Given this list of marker genes RBCK1, BAAT, PHKG2, PALB2, NKX2-5, SLC37A4, RNASEH2B, PGM1, ANK1, PEX14, NR1H4, DUOXA2, SPTB, SLC2A1, PEX12, BRCA2, TPO, VPS50, CYP27A1, DZIP1L, TP53, FH, IL12A, TNPO3, HNF1B, CTRC, PRSS2, F5, MTR, TREX1, PEX10, RINT1, POLG, SLC5A5, VIPAS39, BCS1L, MMEL1, ABCD1, ABCB11, LRP5, SP110, CPOX, KRAS, STX11, LSM11, ASAH1, SEC63, ARL13B, SC5D, POMC, LYST, IFT56, IL2RG, AP1B1, CFTR, SLC2A2, NSD1 (nuclear receptor binding SET domain protein 1), HYOU1, PHKA2, PIGA, COG6, TRMU, GNB2, LIPA (NCBI Gene Id 3988), DEF6, GLIS3, HBG2, TCF4, TULP3, EARS2, DHFR, SMAD4, PKHD1, IRF5, FARSB, KMT2D, CPA1, IL12RB1, IYD, TNFSF15, NPHP3, PERCC1, TFAM, GALM, IFT140, ABCB4, SLC30A10, ARG1, PFKM, PEX5, PEPD, KRT18, DHCR7, TRHR, FOXE1, CEP83, PRSS1, GCLC (glutamate-cysteine ligase catalytic subunit), PCSK1, IFT172, PEX6, HMGCL, ALG6, RNU7-1, HBB, SEC23B, LHX4, KYNU, GFM1, FCGR3B, NKX2-1, STXBP2, BCAP31, PKD2, LBR, HSD17B4, SLC16A2, SLCO1B3, TRAF3IP1, MPV17 (mitochondrial inner membrane protein MPV17), SPOP, CYP7B1, LPL, SLC10A1, NPC1, NBAS, ANKS6, GNAS, PEX3, POU1F1, HK1, LYN, ETFB, SLCO1B1, JAG1, KIF23, CASR, ZFYVE19, RAB27A, ATP6AP1, ABCD3, CCDC115, MST1, RNU4ATAC, HADHB, AP1S1, IARS1, PROP1, TG, SPIB, TJP2, GYPC (glycophorin C (Gerbich blood group)), SPINK1, RFX6, SLC26A4 (solute carrier family 26 member 4), UNC13D, HTRA2, DPAGT1 (NCBI Gene Id 1799), FOCAD, ADAR, ACADVL, ATP11C, PEX11B, BRCA1 (BRCA1 DNA repair associated), SERPINA1, CLDN1, EPB41, TRPV6, SLC51B, CDIN1, CDKN2A, HADHA, SLC25A13, PRKAR1A, KMT2E, PRPS1, GALT, COX4I2, CA5A, ROS1, MMACHC, HSD3B7, MED12, EIF2AK3, RHCE, SCO2, IFIH1, ATP8B1, TBX19, STX5, KIF12, SAMHD1, PIEZO1, SLC44A1, UBR1, NEK8, FGA, PRF1, TSHR, RHD, CASK, G6PD, PEX1, SPTA1, MYO5B, GALK1, CTCF, HESX1, SAA1, IL18BP, GH1, DGUOK, SLC51A, UROS, SPTBN1, PARS2, APC2, ALDOA, VPS33B, ADAMTS13, RNASEH2C, DNASE2, EPB42, ZNF699, PALLD, RHAG, CALR, SHPK, TSHB, SMPD1, ETFA, PEX16, NAA10, POU2AF1, CYP7A1, ALDOB, INSR, COG7, GALE, ALG8, SKIC3, AGR2, GPR35, AMACR, RABL3, RNASEH2A, PKLR, OCLN, PRKCSH, PEX13, GLRX5, ADK, GPI, WDR35, NOTCH2, ATP7A, ETFDH, USP53, PTPN3, POLG2, UNC45A, KCNN4, YARS1, CDAN1, EPCAM, MARS1, PEX26, CDKN1B, PEX2, TMEM67, NPC2, JAK2, TPI1, SEMA4D, DUOX2, LHX3, ABCC2, DCDC2, NEUROG3, SLC4A1, IER3IP1, BLVRA (biliverdin reductase A), ATP7B, AKR1D1, ATP6AP2, FLI1, PAX8, PEX19, UGT1A1, here is a description of the gene set: Human Gene Set: HP_CHOLESTASIS Impairment of bile flow due to obstruction in bile ducts. Cholestasis species: Homo sapiens